The following is a description of a gene set: We aimed to define the proteomic signature of bone marrow (BM) extracellular matrices (ECMs) obtained from patients with monoclonal gammopathy of undetermined significance (MGUS) and multiple myeloma (MM), as compared with healthy donor-derived BM ECMs. We have applied a novel proteomic-based strategy and defined the BM ECM composition in patients with MGUS, newly diagnosed and relapsed MM, compared with healthy donor-derived BM ECM. Peptide abundance, spectral count, number of unique peptides, and the number of identified proteins within the whole BM were measured for both healthy donors and patients with MGUS or MM, either at first diagnosis or at relapse. We began by defining the matrisome of healthy donor-derived BM as the ensemble of proteins detected in at least three independent biological replicates (that is, patients) and by at least three peptides in one of the replicates. Subsequently, we sought to define the proteomic signature for BM ECMs derived from MGUS patients using the same criteria. Comparing the these matrisomes identified proteins expressed by all four groups as well as proteins that are not present until later stages of the disease. This gene set lists the matrisome proteins detected in newly-diagnosed MM patient BM compared to MGUS and relapsed MM-BM. from publication Glavey SV, Naba A, Manier S, Clauser K, Tahri S, Park J, Reagan MR, Moschetta M, Mishima Y, Gambella M, Rocci A, Sacco A, O'Dwyer ME, Asara JM, Palumbo A, Roccaro AM, Hynes RO, Ghobrial IM (PMID 28344315) studied in species Homo sapiens Matrisome proteins detected in newly-diagnosed multiple myeloma (MM) patient bone marrow (BM) compared to MGUS and relapsed MM-BM. Human Gene Set: NABA_MATRISOME_MULTIPLE_MYELOMA, and this is the list of marker genes: COL4A5, ANXA6, LGALS1, CTSS, SERPINA1, ANXA1, CTSC (NCBI Gene Id 50958), CTSD, FGA, ANXA2